Given this list of marker genes Tle6, Nkx2-5, Rapgef1, Mllt3, Gsk3a, G3bp1, Smad4, Tsc2, Ruvbl2, Lect2, Frzb, Otud5, Ctnnd1, Alpk2, Rack1, Mcc, Dab2, Lmbr1l, Sfrp2, Hic1, Ccdc88c, Dkkl1, Wnt11, Znrf3, Hdac1, Bicc1, Sfrp4, Wnt5a, Tmem88b, Dkk1, Csnk1e, Prickle1 (prickle planar cell polarity protein 1), Tpbgl, Wnt5b, Sostdc1, Sox9, Scyl2, Ppp2r3a, Rnf213, Ddit3, Siah2, Isl1, Tmem170b, Tax1bp3, Snai2, Ptpro, Prkn, Lats2, Ctnnbip1, Tmem88, Tbx18, Nkd2, Notum, Dkk4, Sdhaf2, Cdh2, Hmga2, Amer1, Lats1, Mdfi, Nlk, Wif1, Gli3, Fzd1, Barx1, Nphp3, Sox30, Bmp2, Rbms3, Fuz, Csnk1a1, Tle3, Ptpru, Tmem131l, Mad2l2, Dab2ip, Six3, 2210016L21Rik, Sox2, Lrp4, Dact1, Shisa3, Axin2, Ctnnb1, Apc, Apoe, Tsku, Tle1, Gli1, Ubac2, Shisa6, Fgf9, Trabd2b, Frmd8, Sfrp5, Dkk3, Amer2, Cby1, Notch1, Tle7 (NCBI Gene Id 102638837), Sox10 (SRY (sex determining region Y)-box 10), Cdh1 (NCBI Gene Id 12550), Ift80 (NCBI Gene Id 68259), Cav1, Tle4, Ror2, Nkd1, Nfatc4, Pfdn5, Cxxc4, Sox13, Lzts2, Amfr, Lrp6, Foxo1 (NCBI Gene Id 99758), Chd8, Nppa, Grb10, Mesp1 (NCBI Gene Id 17292), Aida, Gsc (goosecoid homeobox), Hdac2, Rnf43, Nxn, Limd1, Tpbg, Asb15 (NCBI Gene Id 78910), Jade1, Apc2, Mir154, Axin1, Gsdma3, Stk3, Egr1, Shh, Grem1, Tcf7l2, Lrp1, Sost, Mdk, Nphp4, Mapk14, Sfrp1, Fzd6, Dkk2, Foxo3, Tle5, Tle2, Cer1, Apcdd1, Cyld, Gsk3b, Dact3, Invs, App, Sox17, Tmem64, Shisa2, Nog (noggin), Cthrc1, Stk4, Fermt1, Stk11, Vgll4, Nherf1, Kremen1, Wwtr1, Gpc3, Wwox, Ankrd6, Asb3, Emd, Draxin, Tnn, here is a description of the gene set: Any process that stops, prevents, or reduces the frequency, rate or extent of the Wnt signaling pathway. species: Mus musculus Mouse Gene Set: GOBP_NEGATIVE_REGULATION_OF_WNT_SIGNALING_PATHWAY